The following is a description of a gene set: species: Homo sapiens Human Gene Set: GOBP_TRNA_5_END_PROCESSING The process in which the 5' end of a pre-tRNA molecule is converted to that of a mature tRNA., and this is the list of marker genes: POP4, POP7, POP5, HSD17B10, TRMT10C, RPP40, PRORP, RPP14, THG1L, POP1, RPP38, RPP25L, SSB, RPP21, RPP25, RPP30